Given this list of marker genes Bad, F2rl1, Clec7a, Ifng, Pomc, Arg1, Fcer2a, Cxcl5, Prf1, Syk, Nos2, Bcl2l11, Cxcl1, here is a description of the gene set: Any process that modulates the frequency, rate or extent of the killing by an organism of cells in another organism. studied in species Mus musculus Mouse Gene Set: GOBP_REGULATION_OF_KILLING_OF_CELLS_OF_ANOTHER_ORGANISM